The following is a description of a gene set: Human Gene Set: ATOH8_TARGET_GENES species: Homo sapiens from publication Yevshin I, Sharipov R, Kolmykov S, Kondrakhin Y, Kolpakov F (PMID 30445619) Genes containing one or more binding sites for (ATOH8) in their promoter regions (TSS -1000,+100 bp) as identified by GTRD version 20.06 ChIP-seq harmonization., and this is the list of marker genes: MIR7-3HG (NCBI Gene Id 284424), TBC1D10A, IFFO1, SH3TC1, EPOR, CBFA2T3, TRBV27, CNOT3, CHRNA1, STRN4, IL34, NDST1, SMAD1, RN7SKP11, SIX5, MDS2, OGDH, MRPL34, EHD1 (EH domain containing 1), SLC22A18, AKAP13, CHD3, GLRA1, RNA5SP152, MGLL, RASGRP3, DEPP1, PPM1F-AS1, GNA15-DT, RDH5, MICAL2, BIN1, SSTR5-AS1, FHL3, BCAR1, PPP1R18, MIDN, ENSG00000226087, PDXK, ZNF491 (NCBI Gene Id 126069), GTF3C1, RALB, RN7SKP249, SVOP, XRCC2, CUEDC1, SSTR5, SNAP25-AS1 (NCBI Gene Id 100131208), RNA5SP60, MIR7-3, HTR5A, HYAL2